The following is a description of a gene set: CpG 1826 binds to Toll-like receptor (TLR)9, whereas influenza virus PR8 activates pDC via TLR7. Differential stimulation of pDCs is expected to result in unique activation mechanism(s) leading to a different phenotypically and functionally matured pDC We used microarrays to detail the global programme of gene expression underlying the maturation process of pDC activated with CpG 1826 and influenza virus PR8. We identified a distinct expression profile of upregulated immunomediators. Genes up-regulated in plasmacytoid dendritic cells (1h): untreated versus influenza virus infection. Human Gene Set: GSE7831_UNSTIM_VS_INFLUENZA_STIM_PDC_1H_UP species: Homo sapiens from publication Iparraguirre A, Tobias JW, Hensley SE, Masek KS, Cavanagh LL, Rendl M, Hunter CA, Ertl HC, von Andrian UH, Weninger W (PMID 18029397), and this is the list of marker genes: S100A4 (S100 calcium binding protein A4), SPCS2, CD38, UAP1L1, FUCA1, DAD1 (defender against cell death 1), ACP3, DDC, STARD4, PMM2, RNF26, NECAP2, FIRRE, PSMB7, MAP1LC3A, SYNJ1, NSDHL, C9orf152, SH3BP2, ACAA2, IGHG1, SH3BGRL3, DDT, SGK1, ZAP70, CDCA8, TBK1, ABHD17A, KLF9, P2RY14, RGS5, MBOAT7, NMB, MAN2A2, PIM3, GCM2, LAMP2, AJUBA, OR4C3, POLR3K, APOBR, TMC6, DDA1, SAPCD2, PLGRKT, CSNK2B, RSU1, C14orf119, MYLIP, TM6SF1, ELL2, CDK2AP2, ASB2 (ankyrin repeat and SOCS box containing 2), FADS2, FGR, UBE2S, WIPF1, SLC28A2, USB1, ID2, PKP4, SESN1 (sestrin 1), PAK6, CRPPA, CDH1, UBASH3A, SERINC3, FDFT1, PIGU, ATP6V0E1 (NCBI Gene Id 8992), CD3E, UROD, IFITM2, LITAF, TGM1, DUSP6, PNPLA7, CDKN3, LGALS3, ARMC3, F2R, SHCBP1, DYNLT1, EBP, ERI1, CKS2, TXNIP, OAT, MED30, SLC39A6, RELCH, USP29, TPP2, PLCG2, PILRB, FGD6, METRNL, DUSP14, ARAF, ATP5MG, ASL, COTL1, H1-4 (H1.4 linker histone, cluster member), LIPE, AQP9, MAF, BET1L, LHX1, MINDY2, CALHM6, SMIM15, SLC26A6, FHL2, ACTN2, SPC25, RNF141, IFI30, SWAP70, HIVEP3, TMEM256, GRK6, KIAA1143, DOCK8, SGMS1, DTNBP1, NUCB1, NDST1, DCP2, LSM12, PTGER3, MYH10, VMAC, DEPDC1, ARHGAP11A, BIRC5, CTSA, OCIAD2, CD52, C2CD2L, TEX9, PROS1, KIF22, ABHD2, PRXL2A, HCLS1, TMEM101, BORA, CD9, GADD45G, UBASH3B, SREBF1 (NCBI Gene Id 6720), RIOX2, CRYBG3, COX5A, CNP, USP20, AKR1C3, MDH1, CECR2, PLEKHO1, IDNK, LPAR6, FRMD6, GATA3, ADARB1, CD1D, GEM, S100A5, XRCC2, PGP, AURKB, H2BC5, CSF2, HRC, PMVK, PDZD11, ASXL2, SHARPIN, SLA2, PSMB8, ARHGAP26 (Rho GTPase activating protein 26), MRPL52 (mitochondrial ribosomal protein L52), NUDT16L1, ABCF3, CLNK, STING1, B3GNTL1, GOLGA7, ACTR3B (actin related protein 3B), AKAP12, AKT1S1, IL4, GGT7, SLC25A1, AHR, COBLL1, ADGRA3, KCNK6, MVD, FGF11